Given this list of marker genes SLC25A22, MAEA, NDUFA4, NDUFS3, UCP1, NDUFAF8, NDUFS5, NDUFB2, PDP2, HSPA9, NDUFAF5, RAB5IF (RAB5 interacting factor), NDUFB1, MT-CO2, MPC1L, SDHC, ETFB, UQCRHL, PDHB, RPS27A (NCBI Gene Id 6233), NDUFB11, NDUFA1, ATP5F1E, NEK1, DMAC2L, NDUFA11, PDHA1, HSCB, NDUFB4, NDUFB6, COX20, COX7A2L, UQCC5, ACAD9, NDUFS8, NDUFV1, MDH2, HIGD1C, PDK4, ETFDH, UQCRB, COQ10B, PDK3, SDHB, MPC2, MT-ND1, ATP5MF, KGD4, SDHAF4, SDHA, COX5A, SLC25A13, SLC25A27, NDUFB5, NDUFA13, ATP5MK, PDK1, TRAP1, SLC25A12, PET100 (PET100 cytochrome c oxidase chaperone), GLO1, LETM1, GOT2, COX7C, NDUFAB1, PC, RMND5B, SDHD, MKLN1, NDUFB3, PM20D1, SURF1, UBC, SUCLG1, MT-ND2, MT-ATP8, CMC1 (NCBI Gene Id 152100), COX7A1, COX4I1, TMEM126A, ATP5MJ, ATP5MC1, ATP5PB, ADHFE1, TMEM177, TMEM126B, GSTZ1, PDPR, COX8C, TMEM186, UQCRFS1, DLAT, NFS1, NNT (NCBI Gene Id 23530), PDK2, MT-ATP6, HIGD2A, PGAM5, MT-CO1, IDH3G, CSKMT, ACAT1, SMIM20, COX16, COX6A1, NDUFA5, NDUFC1, UQCRC2, MT-CO3, LYRM4, ATP5MC2, L2HGDH, IDH3A, RANBP9, GOT1 (NCBI Gene Id 2805), UQCR10, NDUFAF1, NDUFAF4, COA1, PKM, UQCRQ, UQCRC1, COX6B1, OGDH, SCO1, GID8, SUCLA2, HAGH, SLC25A11, FAHD1, NDUFAF7, COX6B2, NDUFS1, TTC19, NDUFA8, SDHAF1 (NCBI Gene Id 651076), NDUFA3, COX8A, NDUFB7, COA3, ME2, UBA52 (NCBI Gene Id 7311), GPT, MT-ND4, ME3, DLD, LDHAL6A, GID4, NDUFA7, SUCLG2, DMAC1, COX11, DMAC2, PKLR, UCP3, MT-ND3, LYRM7, SCO2, LDHC (NCBI Gene Id 3948), PDHA2, COX4I2, COX14, SLC25A4, NDUFS2 (NCBI Gene Id 4720), VDAC1, ATP5F1C, UQCR11, UQCC3, COX5B, NDUFA6, NDUFA10, NDUFA9, LYRM2, LDHAL6B, NDUFS4, PNKD, COQ10A, NDUFAF2, ARMC8, ACO2, NDUFA12, NDUFB9, MDH1, NDUFA2 (NADH:ubiquinone oxidoreductase subunit A2), SFXN4, UQCRH, MT-ND5, MPC1, UQCC6, D2HGDH, NDUFAF3, ISCA2, FOXRED1, UBB, COX6A2, FXN, UCP2, COX15, NDUFS7, PDP1 (NCBI Gene Id 5497), NDUFC2, DLST, ISCU, RMND5A, NDUFV3, ATP5F1B, ATP5MC3 (ATP synthase membrane subunit c locus 3), ATP5F1A (ATP synthase F1 subunit alpha), COX19, COX18, ISCA1, FH, NDUFV2, PYURF, PET117, MT-CYB, COX7B, IDH3B, MT-ND6, COA5 (NCBI Gene Id 493753), TIMMDC1, BCS1L, ATP5PD, ATP5MG (NCBI Gene Id 10632), IDH2, ATP5F1D, ATP5PF, TIMM21, SLC25A14, ME1, ETFA, WDR26, ECSIT, SIRT3 (sirtuin 3), TMEM223, NDUFB10, CYCS, PDHX, SDHAF2 (succinate dehydrogenase complex assembly factor 2), HIGD1A, COX7A2, COX6C, UQCC1, OXA1L, NDUFB8, NUBPL, CYC1 (NCBI Gene Id 1537), UQCC2, NDUFS6, COX17, SLC25A18, TACO1, SDHAF3 (succinate dehydrogenase complex assembly factor 3), SIRT4, CS (NCBI Gene Id 94822), ATP5ME, HCCS (NCBI Gene Id 4307), ATP5PO, LDHA, NDUFAF6, LDHB, here is a description of the gene set: Aerobic respiration and respiratory electron transport studied in species Homo sapiens Human Gene Set: REACTOME_AEROBIC_RESPIRATION_AND_RESPIRATORY_ELECTRON_TRANSPORT